Given this list of marker genes Mef2c, Rflna, Bmp6, Dspp, Matn1, Cd276, Smad3, Dicer1, Phospho1, Mia3, S1pr1, Amtn, Bmpr1a, Fam20c, Osr1 (odd-skipped related transcription factor 1), Hey2 (hairy/enhancer-of-split related with YRPW motif 2), Ahsg (alpha-2-HS-glycoprotein), Mepe, Bcor, Trpm4, Nos3, Atf4, Gata1 (NCBI Gene Id 14460), Enam, Bglap, Fzd9, Adrb2, Bglap3, Ccr1, Vdr, Bmpr2, Ccr1l1, Pth, Asxl2 (NCBI Gene Id 75302), Enpp1, Fgfr3, Bmp4, Ptn (pleiotrophin), Acvr2b, Ifitm5, Nfe2 (nuclear factor, erythroid derived 2), Txlng, Bmp7 (bone morphogenetic protein 7), Slc20a2, Odaph, Acvr1, Acvr2a, Fbn2, Cyp27b1, Ostn, Ptk2b, Fbxo5, Csf1r, Rflnb, Adgrv1, P2rx7, Sgms2, Alox5, Wnt6, Nbr1, Comp, Actn3, Slc4a2, Tmem119, Sox9, Rxrb, Wnt10b, Gja1, Grem1, Rxra, Bmp2, Dmp1, Ltf, Aspn, Ccn1, Isg15, Kl, Tgfb1, Ddr2, Srgn, Ltbp3, Bglap2, Nell1 (NCBI Gene Id 338352), Suv39h1, Wnt4, Fgf23, Twist1, Ecm1, Mgp, Slc8a1, Hif1a, Gas6, Cebpb, Notum, Zmpste24, Hey1, Pkdcc, Tent5a, Tfap2a (NCBI Gene Id 21418), Notch1, Bmp2k, Atp2b1, Bmpr1b, Ank, Osr2, Ano6, Cftr, Gpm6b, Atraid, here is a description of the gene set: Mouse Gene Set: GOBP_REGULATION_OF_BIOMINERAL_TISSUE_DEVELOPMENT Any process that modulates the frequency, rate or extent of biomineral tissue development, the formation of hard tissues that consist mainly of inorganic compounds. studied in species Mus musculus